The following is a description of a gene set: Abnormally increased size of the liver. studied in species Homo sapiens Hepatomegaly Human Gene Set: HP_HEPATOMEGALY, and this is the list of marker genes: PIK3C2A, TET2, MPC1, MRPS7, GALT, DOCK11, CTSA (NCBI Gene Id 5476), RNASEH2A, MT-ND6 (NCBI Gene Id 4541), NCF2, COG6, PTPN11, GLIS3, ERCC1, GNPTAB (NCBI Gene Id 79158), PIEZO1, RAB27A, PIK3CD (phosphatidylinositol-4,5-bisphosphate 3-kinase catalytic subunit delta), EWSR1, HSD17B4, RAC2, POU2AF1, APOC2, ARG1, IL6, SLCO2A1, MMACHC, MECOM, NDUFV1, DHFR, RFXANK, ATAD3A, IGF2, SKIC2, PDGFRB, RMND1 (NCBI Gene Id 55005), IRF1, SLC7A7, CASR, DNASE1L3, HBB (hemoglobin subunit beta), LYRM4, ARPC5, CIDEC, FAH, NDUFAF2, PEX13, ABCA1, RINT1, GCDH, STXBP2, CD55, ITCH, GPD1, KCNH1, NSD2, SLC2A2, FASLG, DVL1, IL2RA, PPP1R21, ICOS, CDKN2A, AGPAT2, IFT140, ATP5MK, YARS1, NUBPL, PIK3R1, VPS33A, SHARPIN, BOLA3, APOA1 (NCBI Gene Id 335), IFNG, RAF1, ZNF699, F5, JAK2, SLC34A2, OSTM1, NLRP3, ANKRD55, RHAG, SAA1, DPAGT1, PSMB4, STX11, DHDDS, TNPO3, GATA2, MPI, TLR8, MYPN, SLC25A20, PEX5, AGR2, SC5D, DPM1, SEMA7A, HMGCS2, PLAAT3, ERCC6, CTNNB1, ABCB4, PARN, MYO5B (NCBI Gene Id 4645), CD27, MYD88, CD96, TNFRSF1B, FLNC, SOS1, G6PC1, COX5A, PEX16, PEX12, G6PC3, SLC4A1, RBM8A, POLD3, NDUFAF5, GBA1, OCLN, NDUFB11, SLC29A3, VPS4A, TRAPPC11, PIGL, NPHP3, ADRA2A, CD3D, SDHD (succinate dehydrogenase complex subunit D), SCN4A (sodium voltage-gated channel alpha subunit 4), DLK1, UNC13D, BMP2, NDUFS4, CYP7B1, TMEM126B, EFL1, COG5, PRKCSH, ABHD5, ALG8, SLC39A4, LARS1, CTLA4, EXTL3, TINF2, CCDC115, TNFRSF11A, LZTR1, APOE, AKT2, TUFM, NFKBIA, FOS, JAK3, NAGA (NCBI Gene Id 4668), RHCE, UQCRB, RBCK1, CASP10, MT-ATP8, RNU4ATAC, FAM111B, MED12, DDRGK1, PSMB10, ABCD3, GALM, PEX10, MT-TL1, SLC25A19, PGM1, NDUFB3, DYNC2LI1, PCCB, ERBB3, ATP6V1B2, MT-TW, VPS11, ABCB11, SAMHD1, KPTN, CA2, SCARB2, CYBB, FOXRED1 (FAD dependent oxidoreductase domain containing 1), HMBS, INPP5E, CNTNAP2, RABL3, ABCC8, ZFYVE19, STAT1, MT-ND5, DHCR7, CALR, PKLR, NRAS, NOP10, NDUFS7, NOTCH2, SOCS1, MPL, IRF8, HSD3B7, IRF5, ALG1, TCF4, COA8, XPR1, HNF1A, OTUD5, VPS33B, NHP2, SRSF2, MTTP, NDUFA11 (NADH:ubiquinone oxidoreductase subunit A11), SLC38A3, TIMMDC1, JAK1, MCM4, GUSB, UCP2, C1QBP, PKHD1, IL12A, NAGS (NCBI Gene Id 162417), RASGRP1, CAVIN1, HJV, PEPD, WT1, GFM1, CTSK, RPGRIP1L, MET, CDAN1, HNF4A, ZIC3, GALK1, SH2B3, ADA2, TRMU, IL18BP, FUCA1, SUCLG1, PRDX1, MAN2B1 (NCBI Gene Id 4125), SLC17A5, NEK8, PUS7, IL12RB1, AGA, GAA, FAS (Fas cell surface death receptor), HYMAI, LBR, TMEM67, MAGT1, CYBA, ERCC8, SLC20A2, LMBRD1, STX5, GNE, GPR35, SLC2A1 (solute carrier family 2 member 1), RRAS2, IL2RB, CYP27B1, SKIC3, SCO2, TP53, AMACR, MARS1, LTBP3, RMRP, GPC3, HMOX1, REL, DPM2, GIMAP5, GNMT, COG1, WRAP53, PSMG2, ZNFX1, KCNQ1, CLDN1, NDUFAF8, NHLRC2, HBA1, GALNS, TMEM70, MRAS, MFN2, ALDOB, AP3B1, RHD, ANK1, NDUFV2, TREX1, GPIHBP1, GALE, FCGR2A, PTPN2, PEX11B, IL2RG, ZAP70, SERPINA1, TRIM37, NLRP1, DLD, CCDC47, SMAD4, EIF2AK3, LIG4, DNAJC21, TCIRG1, NCF1, ASAH1, PSMB8, SLC35C1, BTNL2, PYGL, NDUFS2, DCDC2, MT-ATP6, BRCA1, MAP2K1, IL6ST, KCNJ11, SCO1, RNASEH2B, STAT3, KIF12, ARSB, ETFB, RIT1, PPARG, IFT172, STIM1 (NCBI Gene Id 6786), SPTA1, TERT, IDUA, USP18, CTC1, ALG2, TFE3, SLC25A15, POLD1, TMEM165, NDUFS3, EARS2, ATP5F1A, CYP2R1, STAT4, ADAMTSL2, IL1RN, MST1, HPGD, ALG9, TNFSF11 (NCBI Gene Id 8600), BSCL2, SOX10, HMGCL, NDUFB9, DCLRE1C, KIF20A, KCNQ1OT1, WDR35, LIPA, PRF1, PKD2 (NCBI Gene Id 5311), RRAS, ANTXR1, SCYL1, ASS1, POLG2, CPT2, DKC1, ACADM, EPB42, DGUOK, TSFM, NPC2, KRAS, FERMT3, ATP5F1E, RFT1, TNNI3, NPC1, GBE1, PHEX, SLC25A13, LPL, PTPRC, XRCC4, PALB2, GNB2, ALMS1, TNFRSF1A, PIK3CA, ARL13B, RORC, C2orf69, BMP6, ATP5F1D, CDIN1, CYBC1, PTRH2, TMEM199, ACADVL, FBXL4, GUCY2D, ALDOA (NCBI Gene Id 226), HCK, PLAGL1, TULP3, NEU1, TNFSF15, HFE, PIK3CG, VPS13A, MIF, CD70, CR2, BTD, ATP7B, NDUFS1, NCKAP1L (NCBI Gene Id 3071), HBG2, MPV17, KLF1, HGSNAT, PIGM, SOS2, PEX3, TKFC, ATP8B1, CHD7, TALDO1, MCTS1 (NCBI Gene Id 28985), CDKN1C, SEC63, SPIB, NDUFS8, CD28, XYLT1, FDX2, AUH, INSR, TYMS, LRP5, PEX6, XIAP, RIPK1, KIT, FARSA, SBDS, COG4, JAM2, SEMA4D, MT-TV, INPPL1, STEAP3, IFT122, CLCN7, PSTPIP1, NDUFA6, CPT1A, PDCD1, LYST, AP3D1, MYBPC3, PDGFB, SPIN4, LIPE, IKBKG, MVK, TCN2, PEX26, SPTB, IRF4, SURF1, SLC40A1, GNS, PEX19, ATP6AP1, ASL, MMAA, PHKB, POLG (NCBI Gene Id 5428), SPRED2, LMNA, DNASE2, ATP6AP2, SNX10, AKR1D1, IFT56, DEF6, TRAC, ATRX, KIF3B, MRPS28, RFXAP, CBS, HAMP, NGLY1, NDUFA1, LAMA5, RAG2, MYORG, PCCA, FBN1, IFNGR1, TOGARAM1, ABCC2, SP110, FGA, CBL, PTEN, CD19, ASXL1, SLC22A5, GPC4, MT-ND3, PEX1, ETFA, MT-ND2, PCK1, WDR19, ETFDH, NDUFB10, HBA2, IL7R, PEX14, TNNT2, MT-CYB, RASA2, CD40LG, HYOU1 (hypoxia up-regulated 1), HLA-DRB1 (NCBI Gene Id 730415), PRKCD, ABCA12, MYL2, SNX14, LYN, ERCC4, PALLD, MTX2, MRPL3, XK, SGSH, NAGLU, CD3E (NCBI Gene Id 916), LCAT, NDUFAF4, CTNS, CAV1, ACOX1, PIGS, PHKG2, IFIH1, MT-ND4, KCNN3, IARS1, PTPN22, KCNN4, GCLC (glutamate-cysteine ligase catalytic subunit), TERC, TRPV6, PMM2, ADA, COX14, BAAT, FGFR2, SASH3, SLC30A10, BRCA2, SRP54, PHKA2, FBP1, GLB1, SUMF1, AGGF1, ACAT1, TNFRSF13C, PC, YARS2 (NCBI Gene Id 51067), SH2D1A, SLC19A1, IDS, MT-TE, HAVCR2, B4GALT1, CC2D2A, ADAR, VIPAS39, USB1, PNPLA2, HADHA, BAP1, SLC37A4, VPS45, CPOX, LACC1, SLC25A1, MMAB, MEFV, PIGA, NDUFAF3, CFTR, MADD, RUNX1, ATPAF2, MICU1 (mitochondrial calcium uptake 1), MMUT, NPM1, RTL1, SMPD1, RNASEH2C, MT-TN, DZIP1L, ALG13, MAPK8IP3, TNFRSF13B, DOCK2 (dedicator of cytokinesis 2), MT-TK, ITK, CD81, AGL, MEG3, PLEKHM1, HBG1, MOGS, SF3B1 (NCBI Gene Id 23451), PSAP (prosaposin), RTEL1, NDUFA2, UROS, UBR1, GLRX5, DIS3L2, LPIN2, NDUFS6, LSM11, NCF4, JAM3, FOCAD, COG7, NDUFAF1, PEX2, AHDC1, RNU7-1, MT-ND1, PDGFRA, TGFB1, RAG1, NAE1, RHBDF2, TKT, CD247, HEXB, ALDH1A2, MMEL1, COX4I2, BRAF